Given this list of marker genes CEPT1, KMO, RBM27, CFP, CCNJ, LUC7L3, PACSIN1, TBK1, LPAR6, CEMIP2, RIPOR2, PPM1K, NABP1, MOB1A, MDN1, NXPE4, NXPE2, CD36, CERT1 (NCBI Gene Id 10087), HCST, RBM39, EN2, ULBP1, RBM22, HECA, RPS6, C9orf85, INPP5F, TRIM8, EMC1, FUBP1, DYRK2, ZBTB14, RFX7, CUL3, IFIT1B, MTPN, PRPF4, CLUAP1, FLJ13224, COX20 (cytochrome c oxidase assembly factor COX20), BLOC1S2, B4GALT5, AP3M2, RPL23A, HMG20A, MSL1, ZMYM4, BTBD19, SMAP2, ZDHHC17, TTPAL (NCBI Gene Id 79183), RAB5B, KLHL24, ZBTB43, ITIH2, TAF15, IFI30, TRPS1, TNPO1, CDK17, TASOR, UVSSA, CDK13, SVBP (NCBI Gene Id 374969), PRKACB, OARD1, TRIO, TP53TG5, CTPS2, ARIH2, SF3B1, WIPF1 (WAS/WASL interacting protein family member 1), TMOD3, KMT2D, UBE2D2, MSL2 (MSL complex subunit 2), ARID5B, ATAD2B, PHIP, REST (RE1 silencing transcription factor), TMF1, C2orf68, DENND2D, FYTTD1 (NCBI Gene Id 84248), LDLR, RNF139, SCD, SLAMF6, GIMAP4, SFXN2, GRM5, TCEA3, AP1S2, FBXO33, DPH5, MCCC1, CNTD1, TSPAN32, PLD4, CCDC39, MAX, VPS37B, RRAS2, CYRIB, HEG1, METTL3, CYP27A1 (cytochrome P450 family 27 subfamily A member 1), PARP2, PTCD3, MFHAS1, CORO1A, PDS5A, PKIB, TMEM243 (transmembrane protein 243), PSMG3, LIMD2, TRMT112, RBM33, TMEM245, LYRM9, EMC4, CASP9, CD79A, IQSEC1, AKAP5, RPS6KA3, BAZ2B, MS4A1, PQBP1, DCUN1D1, RNF145, LDHA, TEP1, KANSL3, PEX11G, SLAIN2, ACSS1, PRXL2A, NEDD9, CAPZB, ESRP2, CCNL2, PAIP2, BICRAL, ABHD17B, TNRC6C, FBL, ZNF292, PDE4B, CYTH1, PDZD8, GADL1, MBP, SUN2, STARD9, PLEKHA2, SLTM, GNG10, TMED8, MAPK14, APEX1, ISY1, CD38, HLA-DQA1, BAZ1A, SAMTOR (NCBI Gene Id 154743), SAT1, CHD7, KCTD12, KIAA0040, RNPS1, SIRT7, DDIT4, BTLA, DHX15, ICAM2, RPGRIP1, CYB561A3, PLEK, ST3GAL6, CASP2, CD2AP, PNN, FOXP1, HCLS1, SMIM14, LMO2, TRIM21, GABPB2, CIB1, CNTRL, BIRC3, PPCDC, BMP2K, FAM32A, ZNF329, MTHFD1L, ARMC3, ZNF287, here is a description of the gene set: Human Gene Set: GSE37533_PPARG1_FOXP3_VS_PPARG2_FOXP3_TRANSDUCED_CD4_TCELL_DN We identified Pparg as a major orchestrator of the phenotype of adipose-tissue resident regulatory T cells (VAT Tregs). To explore the contribution of Pparg1 and 2 in the generation of the VAT Tregs-specific gene signatures, CD4+FoxP3- T cells were transduced with Foxp3+/- Pparg1 (or Pparg2), treated with Pioglitazone or vehicle, and double sorted for microarray analysis. species: Homo sapiens from publication Cipolletta D, Feuerer M, Li A, Kamei N, Lee J, Shoelson SE, Benoist C, Mathis D (PMID 22722857) Genes down-regulated in PPARg1 Foxp3 transduced CD4 T cell versus PPARg2 Foxp3 transduced CD4 T cell.